The following is a description of a gene set: species: Mus musculus Catalysis of the hydrolysis of peptide bonds in a polypeptide chain by a mechanism in which the sulfhydryl group of a cysteine residue at the active center acts as a nucleophile. Mouse Gene Set: GOMF_CYSTEINE_TYPE_PEPTIDASE_ACTIVITY, and this is the list of marker genes: Tnfaip3, Bap1, Usp49, Usp47, Cstb, Senp6, Cstdc5, Zup1, Ctsl, Pgpep1l, Zranb1, Cflar, Usp14, Pycard, Capn3, Fetub, Pgpep1, Usp21, Otub1, Usp48, Ctsz, Timm50, Alg13, Csta3, Usp5 (NCBI Gene Id 22225), Capn10, Cst5, Cts6, Senp8, Otulin, Birc6, Usp17lc, Atxn3, Atg4a-ps, Usp4, Adgb, Casp2, Ctsk (NCBI Gene Id 99590), Usp17lb, Cts8, Actmap, Casp1, Usp32 (NCBI Gene Id 77025), Stfa2l1, Usp33, Ltf, Usp18, Capns1 (NCBI Gene Id 52113), Sfrp1, Semp2l1, Scrn1, Capn2, Capns2, Blmh, Ctsm, Capn5, Usp37, Usp9y, 4930486L24Rik, Capn9, Ngp, Gpaa1, Capn15, Mindy4, Ctsb, Ctsr, Kng2, Cst12, Senp2, Usp39, Otud7a, BC051665, Casp4, Cast, Otud3, Ufsp2, Usp46, Usp35, Xiap, Capn12, Kng1, Uchl5, Naip1, Snca, Ctss, Otud6a, Ctsw, Capn11, Ctsll3, Usp7, Tank, Zc3h12a, Usp11, Ctsf, Desi1, Usp50, Cstdc6 (NCBI Gene Id 100038854), Usp44, Atg4a, Capn7, Trhde, Mindy2 (NCBI Gene Id 235461), Cst9, Capn6, Usp42, Usp22, Usp1, Serpinb3b, Casp12, Spock1, Usp34, Usp43, Usp12, Scrn2, Usp24, Usp29, Uchl4, Casp6, Hspd1, Csta1, Nlrp1a (NCBI Gene Id 435266), Brcc3dc, Josd1, Atg4c (autophagy related 4C, cysteine peptidase), Cstdc4, Cst3, Ggh (NCBI Gene Id 667301), Usp40, Cts3 (cathepsin 3, NCBI Gene Id 69006), Otud6b, Usp17le, Brcc3, Atg4d, Casp7, Otud4, Usp45, Josd2, Atg4b, Ctso, Mindy1, Scrn3, Uspl1, Stfa1, Casp9, Nlrp3, Hint1, Otud5, Ctsc, Aim2, Cst13, Usp51 (ubiquitin specific protease 51), Usp36, Casp14, Usp15, Otud7b, Espl1, Cstdc1, Usp10, Usp19, Yod1, Usp16, Arrb1, Usp26, Usp27x, Pttg1, Ctla2b, Uchl3, Senp1, Desi2, Senp7, Cst8, Eif3f, Semp2l2b, Usp20, Usp8, Lgmn, Usp31, Stfa3, Mindy3, Ahsg, Birc7, Cyld (NCBI Gene Id 74256), Cst11, Capn13, Tinagl1, Birc5, Serpinb3c, Cts7, Cstl1, Ctsq, Casp3, Usp17la, Usp54, Bad, Stfa2, Ctsh, Senp5, Otud1 (NCBI Gene Id 71198), Usp30, Usp9x, Serpinb3a, Vcpip1, Csta2, Usp17ld, Semp2l2a, Pigk, Hrg, Usp53, Usp2, Usp25, Uchl1, Usp38, Serpina3g, Casp8, Otub2, Usp28, Serpinb3d, Senp3, Csn2, Ufsp1, Cst7, Cstdc3, Serpinb13, Usp13, Malt1, Usp3, Nlrp1b, Ctsj, Capn1, Capn8, Wfdc2